The following is a description of a gene set: from publication Chen Y, Wang X (PMID 31504780) Human Gene Set: MIR4423_3P Genes predicted to be targets of miRBase v22 microRNA hsa-miR-4423-3p in miRDB v6.0 with MirTarget v4 prediction scores > 80 (high confidence targets). studied in species Homo sapiens, and this is the list of marker genes: RGS4, SCN3A, PHF13, OSBP2, KIF1B, SLAIN2, SLIT1 (NCBI Gene Id 6585), GAN, DIP2A, ARL8B, TRIM23, FSD1L, STON2 (NCBI Gene Id 85439), KPNA4, GJA1 (gap junction protein alpha 1), GK5, KLF5, CADM2, TMEM263, NIPSNAP2, DNAAF5, ANKRD29, RAB3C, SHISA6, TMEM47, NPY1R, NPAT (NCBI Gene Id 8067), GRAMD1B, FMNL2, STK26, SEC24D, PAQR3, PATL2, ABCC9, SGMS2, ATRN, C2orf88, TRIM66, GOLGA6C, SP1, SEC11A, CYYR1, TCF3 (NCBI Gene Id 6929), MESD, HSD17B10, ZNF449, PIK3C2A, VAT1L, SLC44A2, CTNND2, PPM1E, SIX1, PPP1R2, POLR3G, CNOT6L, AQP3, EAF1, CCDC141, KCTD9, PTGES3L, HTR7, GNA13, PREPL, FNDC3B, IFI16 (NCBI Gene Id 3428), CDH9, NR4A2, SNX13, ELOVL5, SPTBN1, HADHB, CPSF4, HCN1, TIMM8A, CDK19, FUT8, FRS2, ADAM10, ANKRD34C, KCTD20, EPB41L5, WNK3, MTMR10 (myotubularin related protein 10), SLC38A2, LANCL1 (LanC like glutathione S-transferase 1), PYGO2, GPC6, JADE3, RTKN2, SOCS5, AMOT, AMER1, LIFR, PMPCB, ADRA2A, ZNF518A, PDSS1, RYR3, DAG1, GAB2, ANKRD50, ANKRD40, CCNK, PLAG1, MTUS2, KAT2B, CCDC71L, ITPR2, SLAIN1, ADAMTS5, GIT2, KIF5B, UXS1, CD84, AFF3, SLC35D1 (NCBI Gene Id 23169), SLK, CRIPTO, LRRTM2, ANKFY1, TRIB3, WIPF3, GAB1 (GRB2 associated binding protein 1), BLOC1S5, ANKHD1, ONECUT2, GRIN2A, NR3C1, TPPP3, AHCTF1